The following is a description of a gene set: studied in species Mus musculus Nucleotide Excision Repair Mouse Gene Set: REACTOME_NUCLEOTIDE_EXCISION_REPAIR, and this is the list of marker genes: Gps1, Rbx1, Polr2e, Pold2, Zfp830, Rpa2, Rfc2, Uba52, Mcrs1, Pold3, Uba52rt, Polr2h, Gtf2h1, Polr2l, Usp7, Yy1, Cops6, Pias3, Pias1 (NCBI Gene Id 72966), Ino80, Isy1, Rps27a, Rfc5, Chd1l, Ube2v2, Mnat1, Actr5, Polr2f, Ercc5, Gtf2h4, Pole, Tcea1, Pcna, Cops5, Ercc2, Xab2, Uvssa, Xrcc1, Ercc4, Sumo2, Rpa1, Polr2b, Ino80c (INO80 complex subunit C), Nfrkb, Rpa3, Ruvbl1, Ercc1, Parp2, Cops2, Aqr, Xpc, Prpf19, Rad23b, Polr2a, Cul4a, Pole2, Xpa, Cops8, Actr8, Cops4, Gtf2h3, Rnf111, Ino80d, Lig1, Lig3, Cdk7, Ercc8, Ube2n, Pold1, Sumo3, Polr2i, Polk, Ddb1, Pole3, Rad23a, Polr2d, Ubb, Ccnh, Actb, Ercc6, Actl6a, Usp45, Parp1, Polr2k, Polr2g, Ubc, Cops7a, Ino80e, Pole4, Pold4, Ino80b, Rfc4, Ddb2, Ube2i, Tfpt, Cul4b, Sumo1, Polr2c, Gtf2h2, Rfc3, Cops7b, Rfc1, Gtf2h5, Cetn2, Cops3, Ercc3